Given this list of marker genes PIK3R5, MTMR3, PIK3CA, PLEKHA1, INPP4B, PIK3R2, PIKFYVE, MTMR6, INPP5E, PTPN13, PLEKHA5, VAC14, MTMR9, SBF2, PI4KB, SACM1L, PLEKHA3, MTMR12, PIK3C2A, ENPP6, PIK3CD, SYNJ1, MTMR8, ARF1, SBF1, PIP4K2C, PIK3R3, RAB5A, PI4KA, PI4K2A, INPP5D, MTMR1, MTMR14, PIP4K2A (NCBI Gene Id 5305), PIK3R1, MTMR4, TPTE, FIG4, PIK3R4, TNFAIP8, RUFY1, TNFAIP8L1, MTMR7, RAB4A, TNFAIP8L2, MTMR10, PIK3CG, PITPNB (NCBI Gene Id 23760), INPPL1, PLEKHA6, GDPD5, PLEKHA2, GDPD3, INPP4A, PIP5K1C, PIK3CB, PIP4P1, PIP4K2B, RAB14 (RAB14, member RAS oncogene family), INPP5F, PNPLA6, TPTE2, INPP5J, PIK3R6, PTEN, OCRL, PIK3C2G, MTMR2, PIP5K1B, MTM1, PLEKHA8, TNFAIP8L3, PIK3C3, BMX, PLEKHA4, PIK3C2B, GDE1, PI4K2B, ARF3, PNPLA7, GDPD1, PIP5K1A, SYNJ2 (NCBI Gene Id 8871), INPP5K, here is a description of the gene set: part of: Phospholipid metabolism species: Homo sapiens Phosphatidylinositol (PI), a membrane phospholipid, can be reversibly phosphorylated at the 3, 4, and 5 positions of the inositol ring to generate seven phosphoinositides: phosphatidylinositol 3-phosphate (PI3P), phosphatidylinositol 4-phosphate (PI4P), phosphatidylinositol 5-phosphate (PI5P), phosphatidylinositol 3,4-bisphosphate PI(3,4)P2, phosphatidylinositol 4,5-bisphosphate PI(4,5)P2, phosphatidylinositol 3,5-bisphosphate PI(3,5)P2, and phosphatidylinositol 3,4,5-trisphosphate (PI(3,4,5)P3). These seven phosphoinositides, which are heterogeneously distributed within cells, can serve as signature components of different intracellular compartment membranes and so help to mediate specificity of membrane interactions. Phosphoinositide levels are tightly regulated spatially and temporally by the action of various kinases and phosphatases whilst PI(4,5)P2 is also a substrate for phospholipase C. The differential localisation of each of these enzymes on specific compartment membranes ensures maintenance of the heterogeneous distribution of phosphoinositides despite the continuous membrane flow from one compartment to another.<br><br>PI is primarily synthesised in the endoplasmic reticulum from where the phospholipid is exported to other compartments via membrane traffic or via cytosolic phospholipid transfer proteins. Phosphorylation of PI to PI4P primarily occurs in the Golgi, where PI4P plays an important role in the biogenesis of transport vesicles such as the secretory vesicle involved in its transport to the plasma membrane. At this place, PI4P has a major function acting as a precursor of PI(4,5)P2, which is located predominantly at this membrane. PI(4,5)P2 binds and regulates a wide range of proteins that function on the cell surface and serves as a precursor for second messengers. Additionally, it helps define this membrane as a target for secretory vesicles, functions as a coreceptor in endocytic processes, and functions as a cofactor for actin nucleation.<br><br>At the plasma membrane, PI(4,5)P2 is further phosphorylated to PI(3,4,5)P3, another phosphoinositide with important signalling functions including stimulating cell survival and proliferation. The inositol 3-phosphatase, phosphatase and tensin homolog (PTEN) regenerates PI(4,5)P2, while the 5-phosphatases convert PI(3,4,5)P3 into the phosphoinositide, PI(3,4)P2, propagating the signal initiated by PI(3,4,5)P3. PI(3,4)P2 is further dephosphorylated in the endocytic pathway by inositol 4-phosphatases to PI3P, the signature phosphoinositide of the early endosomal compartment and a ligand for numerous endosomal proteins. However, the bulk of PI3P is generated directly in the endosomes by phosphorylation of PI. The subsequent endosomal phosphorylation of PI3P to PI(3,5)P2 is believed to generate docking sites for recruitment of cytosolic factors responsible for the control of outgoing traffic from the endosomes. The main localisation and function of the low abundance phosphoinositide PI5P, that can be generated by several pathways, remains to be determined (Krauss & Haucke 2007, Leventis & Grinstein 2010, Roth 2004, Gees et al. 2010, De Matteis & Godi 2004, van Meer et al. 2008, Vicinanza et al. 2008, Lemmon 2008, Kutaleladze 2010, Robinson & Dixon 2006, Blero et al. 2007, Liu & Bankaitis 2010, McCrea & De Camilli 2009, Vicinanza et al. 2008, Di Paolo & De Camilli, 2006). Reactome Pathway: PI Metabolism